Given this list of marker genes Calr, Xpo5, Xpo1, Xpo6, Xpo4, Cse1l, Xpo7, Ranbp17, Eif4enif1, Nup214, Nup42, here is a description of the gene set: Combining with a nuclear export signal (NES) on a cargo to be transported, to mediate transport of a the cargo through the nuclear pore, from the nuclear lumen to the cytoplasm. The cargo can be either a RNA or a protein. studied in species Mus musculus Mouse Gene Set: GOMF_NUCLEAR_EXPORT_SIGNAL_RECEPTOR_ACTIVITY